Given this list of marker genes TRPC1, CCKBR, CD38, RYR2, GNAQ, CCK, GNAI1, DAGLA, RYR1, CNR1, ITPR1, RYR3, PLCB1, here is a description of the gene set: Human Gene Set: WP_CELLTYPE_DEPENDENT_SELECTIVITY_OF_CCK2R_SIGNALING studied in species Homo sapiens Cell-type dependent selectivity of CCK2R signaling